The following is a description of a gene set: Human Gene Set: GOMF_GDP_DISSOCIATION_INHIBITOR_ACTIVITY species: Homo sapiens Prevents the dissociation of GDP from a GTPase, thereby preventing GTP from binding., and this is the list of marker genes: GPSM2, ARHGDIA, RANBP1, CHML, ARHGDIG, CCDC88A (coiled-coil domain containing 88A), GPSM1, RGS14, SH3BP4, GDI1, NGB, EIF5, ITGB1BP1, ARHGDIB, SESN2, GDI2, CHM